The following is a description of a gene set: We have identified more than genes that have upregulated expression in TLR3 activated (PMI-1,2), but have downregulated expression in TLR2 activated (PMP-1,2) macrophages, as compared to control cells (PMC-1,2) from publication de Freitas A, Banerjee S, Xie N, Cui H, Davis KI, Friggeri A, Fu M, Abraham E, Liu G (PMID 22573805) Human Gene Set: GSE36891_UNSTIM_VS_PAM_TLR2_STIM_PERITONEAL_MACROPHAGE_DN species: Homo sapiens Genes down-regulated in peritoneal macrophages: control versus Pam3Cys-Ser-(Lys)4., and this is the list of marker genes: NDUFS2, RINL, MRPL45 (NCBI Gene Id 84311), RPUSD4, FASN, ARHGAP9, FDXR, TBC1D10C, MRPL35, GPX8, KLRG1 (NCBI Gene Id 10219), GNRH1, TRMT1, MICAL1, NT5C, BBS10, RIC8B, GPN1, IFI30, B3GAT3, TBL1X, BIN2, S100A10, OTUB1, AUP1, PAK3, RHBDF1, VPS52, GZMA, C5AR2, MRPL51, MCEE, NFIC, RARG, BBS5, AIFM1, TMEM223, FBXL6, PIAS4, DOK2, NKAIN4, ITGB2, SPACA6 (sperm acrosome associated 6), BET1L, CYP20A1, PDK2, AKT1, HDAC9, PLXDC2, ARFGAP1, NBEAL2, OSBPL5, IMP3, PQBP1, SRSF9, SASH3, IL17RC, SIL1, SCYL1, SERF2, NSUN5, LENG1, EHF, SDHA, PSMG1, PRPSAP1, POLR2I, BRD3, CLK1, GGA3, EIF3B, UBE2L3, MAPKAP1, PIGS, NEPRO, LFNG, PCTP, PDCD11, ZBTB7B, GSTA4, GPR101, TNFRSF13B, AARSD1, PRMT5, BANF1, NCBP2, GATA5, NADK, CARMIL1, CDH8, SF3A1, TNIP1, MRPS18B, ASPRV1, EFEMP1, HYOU1, PSMC2 (proteasome 26S subunit, ATPase 2), NAGPA, GPR157, URGCP, WDR13, COMMD7, DOLK (NCBI Gene Id 22845), IER5, STAMBPL1, GLE1, NDUFA2, GOLM1, RAB29, NOX1, SLC29A3, STXBP2, CCDC125, C9, WBP1, NPRL2, FAM114A2, TM6SF2, PTPN6, TANC2, ATPAF2, PLEKHB2, GSDMD, CAMK2G (calcium/calmodulin dependent protein kinase II gamma), PBX2, NDUFA9, RPS6KA1, ALG3, BOP1, OSGIN1, PRDM10, MR1, EDF1, TAF1D, ATP2A3, KIF1C, C1orf54, DNAJC28, ZBTB24, SMG5, ZBTB42, CTSW, EXTL3, NNMT, HSD3B7, GUCA1B, EIF3D, OSGEP, HDAC7 (NCBI Gene Id 51564), COMMD6, UBE2M, TMEM80, RNF5 (NCBI Gene Id 6048), PGLYRP1, SCNM1, ABCG1, RANBP1